The following is a description of a gene set: Genes down-regulated in MCF7 cells (breast cancer) after knockdown of HIF1A by RNAi. Studies of gene regulation by oxygen have revealed novel signal pathways that regulate the hypoxia-inducible factor (HIF) transcriptional system through post-translational hydroxylation of specific prolyl and asparaginyl residues in HIF-alpha subunits. These oxygen-sensitive modifications are catalyzed by members of the 2-oxoglutarate (2-OG) dioxygenase family (PHD1, PHD2, PHD3, and FIH-1), raising an important question regarding the extent of involvement of these and other enzymes of the same family in directing the global changes in gene expression that are induced by hypoxia. To address this, we compared patterns of gene expression induced by hypoxia and by a nonspecific 2-OG-dependent dioxygenase inhibitor, dimethyloxalylglycine (DMOG), among a set of 22,000 transcripts, by microarray analysis of MCF7 cells. By using short interfering RNA-based suppression of HIF-alpha subunits, we also compared responses that were dependent on, or independent of, the HIF system. Results revealed striking concordance between patterns of gene expression induced by hypoxia and by DMOG, indicating the central involvement of 2-OG-dependent dioxygenases in oxygen-regulated gene expression. Many of these responses were suppressed by short interfering RNAs directed against HIF-1alpha and HIF-2alpha, with HIF-1alpha suppression manifesting substantially greater effects than HIF-2alpha suppression, supporting the importance of HIF pathways. Nevertheless, the definition of genes regulated by both hypoxia and DMOG, but not HIF, distinguished other pathways most likely involving the action of 2-OG-dependent dioxygenases on non-HIF substrates. studied in species Homo sapiens from publication Elvidge GP, Glenny L, Appelhoff RJ, Ratcliffe PJ, Ragoussis J, Gleadle JM (PMID 16565084) Human Gene Set: ELVIDGE_HIF1A_TARGETS_DN, and this is the list of marker genes: PGAP1, P4HA2, EFNA3, P4HA1, MXI1, EGLN3, SPAG4 (NCBI Gene Id 6676), PFKFB3, PLIN2, ILVBL, DPYSL4, LOXL2, CSRP2, CXCR4, EGFR, NDRG1, PGM1, GBE1, FOS, ERO1A, FYN, CYP1A1, SFXN3, KDM4B, PGK1, STC1, CAV1, LOX, CAVIN1, ENO2, OLFML2A, ZNF395, MAGED4B (NCBI Gene Id 81557), INSIG2, FAM162A, PDK1, VLDLR, HLA-DRB1, BNIP3, ATXN1, RRAGD, YEATS2, AK4, HCFC1R1, PAM, QRSL1, IGFBP5, ADM, HILPDA, LOXL1, SH3GL3, TMEM45A, NR3C1, B3GNT4, ANKZF1, RASA4, BNIP3L, SLC2A1, KRT15, EGLN1, ANGPTL4, ZNF292, CCN5, GJA1, STBD1, GLRX, SH2B2, ANG, GYS1, RBPJ, ISG20, DSC2, MAFF, OBSL1, IGFBP3, QSOX1, NOL3, PPFIA4, CA9, WSB1, RNASE4, UPK1A, FAM13A, HK2, SRPX, ALDOC, SCNN1B, S100A4, VEGFC, AHNAK2, PDGFB, CITED2